Given this list of marker genes Eef1a1, Mt1, Rb1, Tial1, Ppia, Impdh2, Prg2, Mtf2, Ran, Bnip3l, Emp3, Myo1c, Jchain, Cdkn1a, Klf9, Sh2d3c, C1qa, Fgfr4, Vasp, Ppm1g, Cct5, Rgl2, Ada, Ubb, Mdm2, Elavl3, Smad5, Spen, Klf13, Gnas, Calr, Ccl19, Itgb7, Ncl, Ptpn11, Gzmb, Creg1, Dad1, here is a description of the gene set: from publication Ma X, Husain T, Peng H, Lin S, Mironenko O, Maun N, Johnson S, Tuck D, Berliner N, Krause DS, Perkins AS (PMID 12130493) Mouse Gene Set: MA_MYELOID_DIFFERENTIATION_UP With the goal of creating a resource for in-depth study of myelopoiesis, we have executed a 2-pronged strategy to obtain a complementary DNA (cDNA) clone set enriched in hematopoietic genes. One aspect is a library subtraction to enrich for underrepresented transcripts present at early stages of hematopoiesis. For this, a hematopoietic cDNA library from primary murine bone marrow cells enriched for primitive progenitors was used as tester. The subtraction used 10 000 known genes and expressed sequence tags (ESTs) as driver. The 2304 randomly picked clones from the subtracted cDNA libraries represent 1255 distinct genes, of which 622 (50%) are named genes, 386 (30%) match uncharacterized ESTs, and 247 (20%) are novel. The second aspect of our strategy was to complement this subtracted library with genes known to be involved in myeloid cell differentiation and function. The resulting cDNAs were arrayed on polylysine-coated glass slides. The microarrays were used to analyze gene expression in primary and cultured murine bone marrow-derived progenitors. We found expression of various types of genes, including regulatory cytokines and their receptors, signal transduction genes, and transcription factors. To assess gene expression during myeloid differentiation, we examined patterns of change during induced differentiation of EML cells. Several hundred of the genes underwent fluctuations in expression level during myeloid cell differentiation. The complete database, accessible on the World Wide Web at http://yale130132115135.med.yale.edu/, allows for retrieval of information regarding these genes. Our microarray allows for genomewide expression analysis of myeloid stem cells, which will help in defining the regulatory mechanisms of stem cell differentiation. Genes up-regulated during myeloid differentiation induced by tretinoin (ATRA) and IL3 in the EML cell line (myeloid progenitor). species: Mus musculus